The following is a description of a gene set: species: Homo sapiens Human Gene Set: GOCC_BBAF_COMPLEX A brain-specific SWI/SNF-type complex that contains eight or nine proteins, including both conserved (core) and nonconserved components; contains the ATPase product of either the SMARCA4/BAF190A/BRG1 gene, the mammalian ortholog of the yeast SNF2 gene, or the SMARCA2/BAF190B/BRM gene, the mammalian ortholog of the Drosophila brm (brahma) gene, or an ortholog of either of these genes. Compared to the neuron-specific nBAF complex  it does not contain DPF1, DPF3 or SMARCC1 or their orthologs. May contain PB1/BAF180., and this is the list of marker genes: ACTB, SMARCA4, ARID1A, SMARCE1, SMARCB1, SMARCD2 (SWI/SNF related, matrix associated, actin dependent regulator of chromatin, subfamily d, member 2), ARID1B (NCBI Gene Id 645070), SMARCA2 (NCBI Gene Id 95083), SMARCC2, ACTL6B